The following is a description of a gene set: Genes down-regulated in comparison of untreated CD4 T cells at 2 h versus the untreated cells at 72 h. The aim of this dataset was to study in detail the transcription kinetics initiated by cytokine IL-4 in early differentiation of Th2 cells. studied in species Homo sapiens from publication Elo LL, Järvenpää H, Tuomela S, Raghav S, Ahlfors H, Laurila K, Gupta B, Lund RJ, Tahvanainen J, Hawkins RD, Oresic M, Lähdesmäki H, Rasool O, Rao KV, Aittokallio T, Lahesmaa R (PMID 20620947) Human Gene Set: GSE17974_2H_VS_72H_UNTREATED_IN_VITRO_CD4_TCELL_DN, and this is the list of marker genes: PCOLCE (procollagen C-endopeptidase enhancer), GNA15, POLR3GL, KDM7A-DT, SELENOW, APPL1, ATP5IF1, RECQL4, CLPP, SLC37A4, VDAC3, SHMT2, APEH, APAF1, SPATA20 (spermatogenesis associated 20), CCNA2, PRDX3, SNRPD2, WDR76, SAPCD1, PYCARD, IMPDH2, SDHAF3, TMEM101, STYXL1, FEN1, AK2, SAMTOR, RWDD2A, CPT2, CPSF3, JMJD6, ACADVL, MTA3, INVS, SRI, TATDN1, FOCAD, RNF144A, TRAF3IP2, N4BP2L1, POLR3K, NPC2, P4HA1, UBE2L6, STIM1 (NCBI Gene Id 6786), DUT (deoxyuridine triphosphatase), EIF2D, MDFIC, RBM41, RHOC, COPS6, CENPI, GALK2, TMEM273, PAICS, TRABD2A, POU2F1, B3GNT2, CD300A, MCTS1, SRGAP2, RNASEH2C, MTFR1, TMEM65 (NCBI Gene Id 286052), SLC39A4, ERCC6L, CD38, GSDMB, DLEU1, ATP5MF, MZB1, SLC9A3-OT1, MPHOSPH9, RNF113A, GALK1, CTNNA1, MLH1, AURKA, MAP3K21, JPT1, PLD3, SNHG33, TBC1D22A, PHPT1, CHCHD3, SRBD1, TIFA, MCEE, MPST, WRAP53, CLNS1A, ANXA11, HMGB2, THEMIS, S100A4, ITGB2, GLB1, LIMS1, NMRK1, H1-3, ORC3, COPG2, MAGEF1, CD226, GLRX3, UQCC3, ZMIZ1, NADSYN1, ASF1B, ARL2, HPRT1, ZDHHC13, ANKRD27, CUEDC2, ERG28, PRMT7, CZIB, FBXL16, MICU1, EIF3J-DT, ARL6IP6, ZNF788P, TXN2, GSS, KIF2A, NXT2, DRAM2, C4orf3, ARHGAP11A, FIG4 (NCBI Gene Id 9896), RHEBL1 (NCBI Gene Id 121268), CKS2 (CDC28 protein kinase regulatory subunit 2), DDB2, ATP5PF, SPINT2, ETHE1, BARD1, SRGAP2C, DTD1, CETN3, DDIT4, CCDC25 (NCBI Gene Id 55246), CCNE2, FBXO22, CBX5, CCNF, NDUFS2, NDUFB5, COX5A, ANO6, PRDX4 (NCBI Gene Id 82852), ACAP1, CBX1, PSD4, SIRT5, SNRNP25, LAYN, NHERF1, PRKAG1, PCBD1, GFM2, COMMD10, DNMT1, CAPNS1, WASHC3, TFB1M, ANGPTL6, STIL, BRCC3, TCF12, MAPKAPK3 (NCBI Gene Id 7867), PSMB8, CREB3, EIF2AK4, CAPG, PXMP2, MYO5A, MPV17, SLC2A3, UBE2Q2P13, ANKRD6, MAP4, PAQR4, PLEKHJ1, VCL, ACOT7, HPCAL1, NDUFA7, TMUB1, PHKB, IFITM2, C4orf46, BEND5, STAP2, GNPAT, PTGR3 (NCBI Gene Id 284273), SORD, CYBC1